The following is a description of a gene set: Any process that stops, prevents, or reduces the frequency, rate, or extent of toll-like receptor 4 signaling pathway. Human Gene Set: GOBP_NEGATIVE_REGULATION_OF_TOLL_LIKE_RECEPTOR_4_SIGNALING_PATHWAY species: Homo sapiens, and this is the list of marker genes: TREM2, TAX1BP1, MIR708, TNFAIP3 (NCBI Gene Id 7128), BPIFB1 (NCBI Gene Id 92747), SQSTM1, MFHAS1, MIR200C, MIR149, MIR200B (NCBI Gene Id 406984), TICAM2, MIR20A (NCBI Gene Id 406982), LYN, RAB7B, ACOD1, TRIM32 (tripartite motif containing 32), MIR140, LILRA2, NR1D1, MIR146A, DAB2IP